The following is a description of a gene set: Genes down-regulated in medullary thymic epithelial cells (mTEC) with CD80 high: AIRE knockout versus wildtype. from publication Derbinski J, Gäbler J, Brors B, Tierling S, Jonnakuty S, Hergenhahn M, Peltonen L, Walter J, Kyewski B (PMID 15983066) Gene expression in different thymic stromal cells and subsets thereof was analyzed in 6-12 week old wild type (C57BL/6) and Aire knock-out (mixed background) mice. Thymic stromal cells were purified by sequential enzymatic digestion (collagenase, collagenase/dispase and trypsin) followed by gradient centrifugation and FACS sorting. Sort criteria were as follows: dendritic cells (CD11c+, F4/80 -), macrophages (F4/80+, CD11c-), cTECs (CD45–/lo, CDR1/Ly51+, Ep-CAM+) and mTECs (CD45–/lo, CDR1/Ly51–, Ep-CAM+). mTECs of wild-type and Aire knock-out mice were further subdivided according to CD80 expression levels. For microarray analysis total RNA from thymic stromal cell samples of two independent experiments was pre-amplified and biotinylated by two rounds of cDNA synthesis and in vitro transcription. Fluorescence readings were evaluated by using Microarray Suite 5.0 software. species: Homo sapiens Human Gene Set: GSE2585_AIRE_KO_VS_WT_CD80_HIGH_MTEC_DN, and this is the list of marker genes: PGAP4 (NCBI Gene Id 84302), LRRC72, CLIC4, TGFBR2, HAPLN3, PACC1, LAG3, S100A6, MAP1S, TEX264, APOBEC1, NAGLU, CCDC32, RAB3IL1, SLC39A12, NAT8L, ESYT2, UNC5D, PDE2A, MAPK13, MBD3, WDSUB1, PRKCA, TBC1D2, SYNGR1, ARHGEF10L, CYP11A1, EIF3J, VPS51, TMEM181, MICAL1, TPTE, VCAM1, TRARG1, RMND5B, VKORC1L1, TTL, FKRP, CAPN15, GPN1, LMLN, IL6ST, TINAGL1, USO1, HIP1, STT3A, SSB, RAB3GAP1, ENC1, OXCT1, RNF181, INF2, NSUN5, TBCC, ABHD4, DTNBP1 (dystrobrevin binding protein 1), PDCD2, ATG3, MFSD12, LAMP2, FARSA, ME3, RSU1, TRAF3IP1, PAK1, METTL1, TMEM270, EPAS1, THAP11, TMEM120A, MIEN1, TRAPPC8, NSDHL, TUBA1B, MAPK8IP1, GSK3B, ZNF14, TMEM53, ADCY4, HADH, PLEKHM1, TBC1D22A, RGL1, ST6GAL1, SLC17A5 (NCBI Gene Id 6479), FAM234B, CYP4A22, WSB2, SPG21, PLCL1, LRP1, MYOF, DIS3L, LAMTOR1, TIMM22, TPGS1, KIF3A, DCTN2, ATP2B1, PRELP, KCNC2, SEPTIN8 (NCBI Gene Id 23176), MECR, SLC39A10, PACS2, SUDS3, ABCC3, LMAN2, TM4SF20, PLPBP, PI4KA, VAMP8, ARHGAP1, LSS (NCBI Gene Id 4047), TSPAN14, CAMK1, NPTX1 (NCBI Gene Id 4884), DOCK10, MTCH1 (mitochondrial carrier 1), TAOK3, JMJD4, TMEM51, LIPA, NPEPL1, AACS, ATP6AP1, EMP3, GPNMB, CMBL, ITGA6, AMDHD2, RHOBTB3, GALC, EIF2B2, APH1B, NOBOX, MYO1E, LGALS1, CADM1, SULF2, MYL6B, HMGCR, EGR2, RAB7A, PROKR1, SQLE, BAG3, RGS2, SRXN1, KLF6, STBD1, GAP43, DIO2, SLC26A3, CHMP7, SLC7A14, SLC29A3, SUN2, NCEH1, LGALS8, MCUR1, LITAF, RCAN2 (NCBI Gene Id 221402), COL4A5, PISD (phosphatidylserine decarboxylase), KRAS (KRAS proto-oncogene, GTPase), PDP1, COPG2, LCT, SAMM50, SPICE1 (NCBI Gene Id 152185), ATP23, IRAG2, SCARB1, PCBP1, PSMD13, CTSA, LRIT2, MED22, HNF1A, ABHD12, CEP128, TRMT61A, WDR91, ZFP82, MVP, TSPAN13 (NCBI Gene Id 27075), CNRIP1, CLPTM1L, PPP1CA, ABHD1, HOXA4, VWA5A, MPZL1 (myelin protein zero like 1), ANKH, ALPK1, CRIP1, HRAS, NIPAL3, ARFGEF3